The following is a description of a gene set: Mouse Gene Set: GOBP_NEGATIVE_REGULATION_OF_GONAD_DEVELOPMENT Any process that stops, prevents or reduces the frequency, rate or extent of gonad development. studied in species Mus musculus, and this is the list of marker genes: Asmt, Nr5a1, Wnt4, Wt1, Zfpm2